Given this list of marker genes GSTP1, CORO1B, SLIT2, AIF1, MIR34A, here is a description of the gene set: Any process that stops, prevents, or reduces the frequency, rate, or extent of smooth muscle cell chemotaxis. studied in species Homo sapiens Human Gene Set: GOBP_NEGATIVE_REGULATION_OF_SMOOTH_MUSCLE_CELL_CHEMOTAXIS